Given this list of marker genes GNB5, PANX1, PRKAR2B, MAPKAP1, GNAQ, CTNNB1, GNAS, CACNB3, CDH5 (NCBI Gene Id 1003), GNG12, TLN1, GNG2, ITGAV, NFKBIA, STAT1, RAMP2, PRKACB, KDR, P2RY2, PRR5, GNG10, MTOR, RICTOR, ADCY1, GNB4, GNG8, ITGA5, GNGT2, GNG13, CACNA1H, GNB1, IKBKB, SPP1, PDE4D (phosphodiesterase 4D), GNG3, GJA1, PIK3CD, GNG11, ABL1, PTK2, CACNA2D1, ADCY8, ADCY4, PIK3CB, PIK3CA (phosphatidylinositol-4,5-bisphosphate 3-kinase catalytic subunit alpha, NCBI Gene Id 5290), CAPNS1, MLST8, ADCY9, ADCY2, ADCY7, FYN, AKT1, PPP2CA, GNB2, PRKACA, ITGB3, NOS3, PIEZO1, CACNG7, GNG7, GNG5, PECAM1, CACNB2, P2RX7, PPP2R1A, MMP14, GNB3, NLRP3, HSPG2, PRKACG, IKBKE, CHUK, ADCY5, FLT4 (NCBI Gene Id 7909), PDPK1, NFKB1, YAP1, CALCRL, CACNB1, PRKAR1A, ANXA2, GNG4, CALM1, CAPN2, ADM, PPP2R2A, TRPV4, IKBKG, ADCY3, PIK3R2, PKN2, RELA, VCL, CAPNS2, GNGT1, PRKAR2A (NCBI Gene Id 5576), PRKAR1B, GNA11, PPP2R1B, FN1, ADCY6, ITGB1, PTPN1, here is a description of the gene set: species: Homo sapiens part of: Cellular responses to stimuli Molecular mechanosensors are biomolecules that convert a physical force into an intracellular chemical signal. One of the most common types of mechanosensor is the mechanically gated ion channel such as PIEZO1. Other mechanosensors include integrins and receptors such as AGTR1 and GPR68. After activation by force, mechanosensors then activate mechanotransducers such as kinases and channels to amplify and transfer the signal to chemical processes that produce downstream effects such as changes in gene expression, cell growth, and behavior.<br>Mechanosensors and mechanotransducers enable endothelial cells to respond to laminar and turbulent blood flow, osteocytes to respond to mechanical load and fluid flow, and specialized cellular structures such as Merkel cells and Pacinian corpuscles to respond to touch. Reactome Pathway: Cellular responses to mechanical stimuli